The following is a description of a gene set: from publication Korkola JE, Houldsworth J, Chadalavada RS, Olshen AB, Dobrzynski D, Reuter VE, Bosl GJ, Chaganti RS (PMID 16424014) Adult male germ cell tumors (GCTs) comprise distinct groups: seminomas and nonseminomas, which include pluripotent embryonal carcinomas as well as other histologic subtypes exhibiting various stages of differentiation. Almost all GCTs show 12p gain, but the target genes have not been clearly defined. To identify 12p target genes, we examined Affymetrix (Santa Clara, CA) U133A+B microarray ( approximately 83% coverage of 12p genes) expression profiles of 17 seminomas, 84 nonseminoma GCTs, and 5 normal testis samples. Seventy-three genes on 12p were significantly overexpressed, including GLUT3 and REA (overexpressed in all GCTs) and CCND2 and FLJ22028 (overexpressed in all GCTs, except choriocarcinomas). We characterized a 200-kb gene cluster at 12p13.31 that exhibited coordinated overexpression in embryonal carcinomas and seminomas, which included the known stem cell genes NANOG, STELLA, and GDF3 and two previously uncharacterized genes. A search for other coordinately regulated genomic clusters of stem cell genes did not reveal any genomic regions similar to that at 12p13.31. Comparison of embryonal carcinoma with seminomas revealed relative overexpression of several stem cell-associated genes in embryonal carcinoma, including several core stemness genes (EBAF, TDGF1, and SOX2) and several downstream targets of WNT, NODAL, and FGF signaling (FGF4, NODAL, and ZFP42). Our results indicate that 12p gain is a functionally relevant change leading to activation of proliferation and reestablishment/maintenance of stem cell function through activation of key stem cell genes. Furthermore, the differential expression of core stem cell genes may explain the differences in pluripotency between embryonal carcinomas and seminomas. Top 25 most highly expressed genes in embryonic carcinoma relative to seminoma tumors. species: Homo sapiens Human Gene Set: KORKOLA_EMBRYONIC_CARCINOMA_VS_SEMINOMA_UP, and this is the list of marker genes: WNT5B, ABCG2, VCAN, KRT18 (NCBI Gene Id 3875), SCNN1A, RASSF8, GPM6B, CD24, SOX2 (SRY-box transcription factor 2), NAP1L1, ERRFI1, GPC3, CALB1, GAL, DNMT3B, GDF3, CD24P2 (CD24 molecule pseudogene 2), FGF4, GPC4, GJA1, SP8, CRIPTO, STK26, BCAT1